Given this list of marker genes Ptk7, Spag6l, Tcf15, Ift20, Ajap1, Foxf1, Syne4, Fat1, Myo9a (myosin IXa), Rhoa, Nherf1, Trp63, Zdhhc7, Ttc8, Scrib, Ahi1, Crb3, Dlg5, Lama1 (NCBI Gene Id 16772), Msn, Rab10, Ophn1, Cdc42, Sh3bp1, Wnt5a, Camsap3, here is a description of the gene set: Mouse Gene Set: GOBP_POLARIZED_EPITHELIAL_CELL_DIFFERENTIATION species: Mus musculus The process in which a relatively unspecialized cell acquires specialized features of a polarized epithelial cell. The polarized epithelial cell can be any of the cells within an epithelium where the epithelial sheet is oriented with respect to the planar axis.